Given this list of marker genes SOX4, STAT5A (signal transducer and activator of transcription 5A), NCKAP1L, LILRB1, SYK, SOX13, STAT5B, EGR3, LEF1, LCK, PTPRC, TCF7, NOD2, here is a description of the gene set: Human Gene Set: GOBP_REGULATION_OF_GAMMA_DELTA_T_CELL_ACTIVATION Any process that modulates the frequency, rate or extent of gamma-delta T cell activation. studied in species Homo sapiens